The following is a description of a gene set: Any process that activates or increases the frequency, rate, or extent of type I interferon production. Type I interferons include the interferon-alpha, beta, delta, episilon, zeta, kappa, tau, and omega gene families. Mouse Gene Set: GOBP_POSITIVE_REGULATION_OF_TYPE_I_INTERFERON_PRODUCTION studied in species Mus musculus, and this is the list of marker genes: Chuk, Tlr8, Rab2b, Irf7 (interferon regulatory factor 7), Uap1, Zbtb20, Mavs, Tank, Tlr3, Gbp4, Arrdc4, Dhx9 (NCBI Gene Id 98320), Ifih1, Traf6, Nmb, Ticam1, Oas1g, Polr3c, Tlr2, Ticam2, Irf3, Trim65, Clec12a, Hspd1, Riok3, Oas1f, Flt3, D1Pas1, Zcchc3, Polr3a, Traf3ip3, Stat1, Traf3, Kpna2, Hsp90aa1, Gapdh (glyceraldehyde-3-phosphate dehydrogenase), Tomm70a, Ddx3x, Setd2, Oas1c, Oas1d, Irak1, Polr3d, Tlr9, Tbk1, Rnf135, Hmgb1, Trim56, Irf1, Ptpn22, Gapdhrt, Gapdhrt2, Pqbp1, Garin5a, Nmbr, Oas1a, Polr3f, Tradd (NCBI Gene Id 71609), Rigi, Zc3hav1, Kpna2rt, Mmp12, Trim15, Polr3g, Flot1 (flotillin 1), Sting1, Dhx36, G3bp1, Oas1b, Dhx58, Xiap, Plcg2, Myd88, Ifnar1, Oas2, Polr3b, Oas3, Dhx33, Gapdh-ps15, Cd14, Tlr4 (NCBI Gene Id 21898), Isg15, Oas1h, Hmgb2, Ikbke, Tlr7, Ptpn11, Irf5, Usp22, Syk, Cgas, Oas1e